The following is a description of a gene set: species: Mus musculus Mouse Gene Set: REACTOME_ASPARAGINE_N_LINKED_GLYCOSYLATION Asparagine N-linked glycosylation, and this is the list of marker genes: Trappc3, Alg5, Ubb, B4galt3, Copb2, Copg2, Fcsk, Kdelr3, Nudt14, Gfpt1, Tubb2b, Sec24d, B4galt5, Glb1, Glt28d2, Tubb4a, Trappc5, Asgr2, Mgat2, Cog3, Tuba3b, Nanp, Sar1b, Dpagt1, Mpi, Sec22b, Sec22a, Capza3, Sec16a, Trappc1, Chst8, Alg2, Amdhd2, Cog4, Tubal3, St6galnac5, Sptbn4, St3gal5, Nagk, Ins1 (NCBI Gene Id 16333), Srd5a3, Fpgt, Fuca1, Rps27a, St8sia2, Gnpnat1, Mia3, Alg8, St3gal4, Copb1 (coatomer protein complex, subunit beta 1), Cnih3, Tuba4a, Copg1, Umod, Mgat4c, Ngly1, Tuba1c, Capza2, Nsf, Mvd, Tubb4b, Cd59b, Pdia3, Trappc6a, Renbp, Trappc2, Gmppa, Tbc1d20, Mia2, Dync1li1, Trappc10, Cnih1, Gosr2, Napb (NCBI Gene Id 56276), Tubb1, Gm20716, Sptbn1 (spectrin beta, non-erythrocytic 1), Trappc4, Dctn6, Preb, Tuba3a, Ykt6, St3gal1, Tuba1a, Lman2l, B4galt4, Trappc2l, Mgat1, Sec23a, Scfd1, Rab1a, B4galnt2, Lman1, Dpm3, B4galt1, Ppp6r3, Sptbn5, Neu3, Tubb6, Alg6, Tubb2a, Trappc9, Alg12, Actr1a, Dctn4, Pgm3, Csnk1d, Sec13, Cd55, St8sia3, Bet1l, Trappc6b, Copz2, Npl, Nus1, Alg14, Sec31a, Tubb3, Alg1, Derl1, Ppp6c, F8, Arf5, St6galnac3, Asgr1, Sptan1, Calr, Gne, Uba52, Copz1, Stx17, Tuba1b, Slc35c1, Engase, Dync1li2, Arfgap1, Slc35a1 (solute carrier family 35 (CMP-sialic acid transporter), member 1), Tgfa, Alg3, Arfgap3, Gfpt2, Alg9, Lman2, Kdelr1, Cnih2 (NCBI Gene Id 12794), Sec24b, Rab1b, Dctn3, Man2a2, Cog2, Areg (NCBI Gene Id 11839), Bet1, Copa, Gmppb, Lman1l, St6galnac4, Sec24c, Sec24a, Ctsa, St6galnac2, Mgat3 (mannoside acetylglucosaminyltransferase 3), Napa, Neu4 (NCBI Gene Id 241159), Uso1, Cog6, Mgat4a, Golga2, Manea, Cope, Gosr1, Mgat5, St6gal2, Mpdu1, Dctn1, Golgb1, Sptbn2, Cog7, Dolk, Sec16b, St8sia5, Dctn5, B4galt6, Gbf1, St3gal3, Arcn1, Gmds, Serpina1c, Arf1, St8sia6, Stx5a, Fuom, St6gal1, Sec31b, F5, St6galnac6, St6galnac1, Tfg, Sec23ip, Tmed9, Pmm1, Arfgap2, Tmed7, Pmm2, Nans, Lhb, Dhdds, Dynll1, Ubxn1, Uap1, St3gal2, Folr1, Ppp6r1 (NCBI Gene Id 76753), Ubc (ubiquitin C), Man1a, Psmc1, Gorasp1, B4galt2, Sec22c, Neu2, Dpm2, Dync1h1, Dync1i1, Arf4, Sptb, Ctsc, Gria1, Amfr, Fut8, Tmed3, Gfus, Ankrd28, St8sia4, Napg, Cog8 (component of oligomeric golgi complex 8), Chst10, Mcfd2, Serpina1b, Mgat4b (mannoside acetylglucosaminyltransferase 4, isoenzyme B), Ctsz, Neu1, Rad23b, Kdelr2, Tmed2, Cog1, Dctn2, Tmed10, Cmas, Slc17a5, Tmem115, Canx, Dynll2, Hk1, Dpm1, Vcp, Arf3, Man2a1, Capzb, Man1a2, Spta1, St8sia1, Cga, St3gal6, Actr10, Cog5, Col7a1, Dolpp1, Dync1i2, Ank1, Tuba8, Man1c1, Uba52rt